The following is a description of a gene set: DNA microarrays can be used to identify gene expression changes characteristic of human disease. This is challenging, however, when relevant differences are subtle at the level of individual genes. We introduce an analytical strategy, Gene Set Enrichment Analysis, designed to detect modest but coordinate changes in the expression of groups of functionally related genes. Using this approach, we identify a set of genes involved in oxidative phosphorylation whose expression is coordinately decreased in human diabetic muscle. Expression of these genes is high at sites of insulin-mediated glucose disposal, activated by PGC-1alpha and correlated with total-body aerobic capacity. Our results associate this gene set with clinically important variation in human metabolism and illustrate the value of pathway relationships in the analysis of genomic profiling experiments. Human Gene Set: MOOTHA_PYR from publication Mootha VK, Lindgren CM, Eriksson KF, Subramanian A, Sihag S, Lehar J, Puigserver P, Carlsson E, Ridderstråle M, Laurila E, Houstis N, Daly MJ, Patterson N, Mesirov JP, Golub TR, Tamayo P, Spiegelman B, Lander ES, Hirschhorn JN, Altshuler D, Groop LC (PMID 12808457) species: Homo sapiens Genes involved in pyruvate metabolism; based on literature and sequence annotation resources and converted to Affymetrix HG-U133A probe sets., and this is the list of marker genes: PDK4, PDHA2, PDK1, PDHX, PDHA1, PDP1, PDHB, PDK3